Given this list of marker genes Itgb5 (integrin beta 5), Septin4, Sox8, Gsn, Aqp4, Sparcl1, Matn4, Itgam, Hepacam, Zfp607b, Slc6a20b, Mt1, Magi1, Dip2a, Plpp3, Aldoc, Glul, Ncan, Gja1, Sparc, Pla2g7, Emx2, Atp1a2, Cldn5, Apoe, Bcan, Gfap, Gldc, Atp1a4, Dbi, Id3 (NCBI Gene Id 15903), Cst3, Gpr37l1, Clu, Cd63, S1pr1, Mfge8, Lyz2, Stab1, Atp13a5, Prdx6, C1qa, Mlph, here is a description of the gene set: Molecular approaches to understanding the functional circuitry of the nervous system promise new insights into the relationship between genes, brain and behaviour. The cellular diversity of the brain necessitates a cellular resolution approach towards understanding the functional genomics of the nervous system. We describe here an anatomically comprehensive digital atlas containing the expression patterns of approximately genes in the adult mouse brain. Data were generated using automated high-throughput procedures for in situ hybridization and data acquisition, and are publicly accessible online. Newly developed image-based informatics tools allow global genome-scale structural analysis and cross-correlation, as well as identification of regionally enriched genes. Unbiased fine-resolution analysis has identified highly specific cellular markers as well as extensive evidence of cellular heterogeneity not evident in classical neuroanatomical atlases. This highly standardized atlas provides an open, primary data resource for a wide variety of further studies concerning brain organization and function. Mouse Gene Set: LEIN_ASTROCYTE_MARKERS from publication Lein ES, Hawrylycz MJ, Ao N, Ayres M, Bensinger A, Bernard A, Boe AF, Boguski MS, Brockway KS, Byrnes EJ, Chen L, Chen L, Chen TM, Chin MC, Chong J, Crook BE, Czaplinska A, Dang CN, Datta S, Dee NR, Desaki AL, Desta T, Diep E, Dolbeare TA, Donelan MJ, Dong HW, Dougherty JG, Duncan BJ, Ebbert AJ, Eichele G, Estin LK, Faber C, Facer BA, Fields R, Fischer SR, Fliss TP, Frensley C, Gates SN, Glattfelder KJ, Halverson KR, Hart MR, Hohmann JG, Howell MP, Jeung DP, Johnson RA, Karr PT, Kawal R, Kidney JM, Knapik RH, Kuan CL, Lake JH, Laramee AR, Larsen KD, Lau C, Lemon TA, Liang AJ, Liu Y, Luong LT, Michaels J, Morgan JJ, Morgan RJ, Mortrud MT, Mosqueda NF, Ng LL, Ng R, Orta GJ, Overly CC, Pak TH, Parry SE, Pathak SD, Pearson OC, Puchalski RB, Riley ZL, Rockett HR, Rowland SA, Royall JJ, Ruiz MJ, Sarno NR, Schaffnit K, Shapovalova NV, Sivisay T, Slaughterbeck CR, Smith SC, Smith KA, Smith BI, Sodt AJ, Stewart NN, Stumpf KR, Sunkin SM, Sutram M, Tam A, Teemer CD, Thaller C, Thompson CL, Varnam LR, Visel A, Whitlock RM, Wohnoutka PE, Wolkey CK, Wong VY, Wood M, Yaylaoglu MB, Young RC, Youngstrom BL, Yuan XF, Zhang B, Zwingman TA, Jones AR (PMID 17151600) species: Mus musculus Genes enriched in astrocytes in the adult mouse brain identified through correlation-based searches seeded with the astrocyte cell-type specific gene expression patterns.